The following is a description of a gene set: Marker genes curated from the annotated cluster as represented in the Descartes Human Gene Expression During Development database. studied in species Homo sapiens The gene expression program underlying the specification of human cell types is of fundamental interest. The study authors generated human cell atlases of gene expression and chromatin accessibility in fetal tissues. For gene expression, the study authors applied three-level combinatorial indexing to >110 samples representing 15 organs, ultimately profiling ~4 million single cells. The study authors leveraged the literature and other atlases to identify and annotate hundreds of cell types and subtypes, both within and across tissues. Our analyses focused on organ-specific specializations of broadly distributed cell types (such as blood, endothelial, and epithelial), sites of fetal erythropoiesis (which notably included the adrenal gland), and integration with mouse developmental atlases (such as conserved specification of blood cells). These data represent a rich resource for the exploration of in vivo human gene expression in diverse tissues and cell types. Human Gene Set: DESCARTES_FETAL_INTESTINE_ENS_NEURONS from publication Cao J, O'Day DR, Pliner HA, Kingsley PD, Deng M, Daza RM, Zager MA, Aldinger KA, Blecher-Gonen R, Zhang F, Spielmann M, Palis J, Doherty D, Steemers FJ, Glass IA, Trapnell C, Shendure J (PMID 33184181), and this is the list of marker genes: NSG2, ARHGDIG, CNTN1, KIF5A, LHFPL5, VIP, NYAP1 (neuronal tyrosine phosphorylated phosphoinositide-3-kinase adaptor 1), CPLX1, TMC3, ATP2B2, CTNNA2, LTK, CNTNAP2, RPL36P6, HMGN1P14, FAM222A-AS1, CELF5, CADM3, CHRNA4, SPOCK1, SYT2, NOS1, CHRNA7, HEATR5A, MYH15, CHAT, CHD5, ATP2B3, ACTL6B, SLCO5A1-AS1, CACNA1E, TPBGL-AS1, TLX2, GAL, CEND1, HRH3, PDIA2, PHOX2A, HS3ST5, INA, DCX, GNG8, ENTPD3, SLC18A3, CSMD1, GCGR, LINC01776, SORCS3, GAP43, NEFM, JAKMIP1-DT, PLPPR3, MAST1, MLLT11, DBH, PHACTR3, SLC6A2, CNTN5, MIR137HG, SLC10A4, ENSG00000226454, STMN4, PHOX2B-AS1, PALM3, OLFM1, PLPP4, TLCD3B, DRGX, CACNG2, HMX2, HTR3B, FAM163A, TAGLN3, CNR1, SLIT1, CNTNAP5, STMN2, PIRT, LIX1, SRRM4, TRIM67, MAP6, NCAM2, IQCJ, LINC00609 (NCBI Gene Id 101101773), DCLK1 (doublecortin like kinase 1), SYT1, ELAVL3, TTC9B, HOXB5, ATP6V1G2, PSD2 (NCBI Gene Id 84249), GRP, CRABP1 (NCBI Gene Id 1381), GPR176 (NCBI Gene Id 11245), ZNG1E, PENK, SLC6A15, RIT2, MAPT, SYT9 (synaptotagmin 9), F12, TH, CNTNAP5-DT, TMEM151B, STUM, DLX3, OPRD1, DNER, DPP6, JPH3, FIBCD1, KCNJ5, EEF1A2, LINC01315, DOCK3, SGIP1, JAKMIP1, NRSN1, TUBB2A, ELAVL4, PTPRR (protein tyrosine phosphatase receptor type R), NXPH4, LINC01561, C4orf50, MYT1L, ASTN2, EML5, SYN3, NMNAT2, KCNH5, CUX2 (NCBI Gene Id 23316), GPR22 (G protein-coupled receptor 22), LINC02198, PRPH (peripherin), GNG3, ATP1A3, ERC2, SNAP91, ASTN1, LINC01250, ATCAY, PTPRO, SMIM28, VAT1L (vesicle amine transport 1 like), MAP1B, KCND2, CNGB1, ZCCHC12, CELSR1P1, HECW1, FGF13, CACNG7, KIAA0408, ADCYAP1, UCHL1, TUBB4A, NDRG4, JPH4, HECW1-IT1, TUBB2B